The following is a description of a gene set: Genes differentially expressed in ES cells with DPPA4 knockout. from publication Madan B, Madan V, Weber O, Tropel P, Blum C, Kieffer E, Viville S, Fehling HJ (PMID 19332562) species: Mus musculus Mouse Gene Set: MADAN_DPPA4_TARGETS Dppa4 (developmental pluripotency-associated 4) has been identified in several high-profile screens as a gene that is expressed exclusively in pluripotent cells. It encodes a nuclear protein with an SAP-like domain and appears to be associated preferentially with transcriptionally active chromatin. Its exquisite expression pattern and results of RNA interference experiments have led to speculation that Dppa4, as well as its nearby homolog Dppa2, might play essential roles in embryonic stem (ES) cell function and/or germ cell development. To rigorously assess suggested roles, we have generated Dppa4-deficient and Dppa4/Dppa2 doubly deficient ES cells, as well as mice lacking Dppa4. Contrary to predictions, we find that Dppa4 is completely dispensable for ES cell identity and germ cell development. Instead, loss of Dppa4 in mice results in late embryonic/perinatal death and striking skeletal defects with partial penetrance. Thus, surprisingly, Dppa4-deficiency affects tissues that apparently never transcribed the gene, and at least some loss-of-function defects manifest phenotypically at an embryonic stage long after physiologic Dppa4 expression has ceased. Concomitant with targeted gene inactivation, we have introduced into the Dppa4 locus a red fluorescent marker (tandem-dimer red fluorescent protein) that is compatible with green fluorescent proteins and allows noninvasive visualization of pluripotent cells and reprogramming events., and this is the list of marker genes: Mep1b, Dnajc6, Usp17la, Nefh, Cfap144, Eif1ad8, Hck, Acot1, Serpinb6c, Gm7104, Tuba3a, Prpf39, Gad1, Hormad1 (HORMA domain containing 1), Ndufb11b, Rhox5, Cyct, Tex19.1, Gtsf1, Plekhg1, 8030474K03Rik, Alyreffm14, Gli1, Tek, Stk31, Tcstv1a, Dmrtc1c1, Msantd5f1, Gm13043, Rhox13, 4930503E14Rik, Pramel39-ps, Hook1, Aard, Abcb1a, Gpx2, Rec114, Chfr, Iqcg, Ttpa, Spink1, Dppa4, Rasip1, Car4, Prrc1, Sohlh2, Cisd3, Ap1s3, Clca3b, Tcstv2c, Gm21283, Eif1ad15, Fthl17e, Spesp1, Naa11, Pdcl2, Calb2, She, Aurkc, Mael, Myo1f, Sntb1, Syce1, Rhox6, Snap91, Dazl, Zscan4c, Slc25a31, Neurod1, Xlr3a, Rnf17, Ddx4, Timm8a2, Klhl13